The following is a description of a gene set: Human Gene Set: HP_ABNORMAL_NASAL_MUCUS_SECRETION Abnormal nasal mucus secretion studied in species Homo sapiens Any deviation from the normal quantity of secretion of nasal mucus, a thick viscous liquid produced by the mucous membranes of the nose., and this is the list of marker genes: LRRC56, CCDC39, ODAD1, SDHD, SREBF1, CCDC40, DNAH1, SCN9A